Given this list of marker genes Serpine2, Ppard, Dynll1, Serpinc1, Rangap1, Arhgap23, Prss22, Inka1, Aph1b, Lgmn, Ercc5, Rictor, Tnfrsf10b, Rgs18, Serpina3c, Rptor, Cd55, Pdzd11, Naip6 (NCBI Gene Id 272660), Frmd7, Ccnd2, Serpinb1a, Igfbp3, Krtcap2, Chn2, Serpinb5, Dennd6b, Noxa1, Arhgap42 (NCBI Gene Id 71544), Dennd2d, Grtp1, Rubcn, Stx4a, Sos1, Ppp2r1b, Agfg1, Ppp2r2d, Timp2, Ppp1r15a, Spock3, Scgb1a1, Ppp1r1c, Rapgef2, Eef1b2, Serpina1d, Csnk2b, Guca2b, Lrp6, Pak2, Ghrl, Gprc5b, Mycbp2, Birc5, Slc27a1, Nherf4, Wrnip1, Ppef2, Rgs11, Bcl2l1, Dpep1, Ppp4r4, A2m (NCBI Gene Id 232345), Cdca2, Eed, Cmya5, Tnfaip8, Eps8l3, Rabep1, Lars1, Dennd4a, Afap1l2, Arhgef16, Prdx3, Vsir, Iqsec2, Acap2 (ArfGAP with coiled-coil, ankyrin repeat and PH domains 2), Pik3r1, Abi1, Lck, Hsp90ab1, Ctsh, Cstdc4, Bmp2k, Serpina6, Stxbp5l, Ppp6r1, Agap3, Rapgef1, Map3k12, Wfdc2, Dnaja3, Limk1, Serpina1a, Wbp11 (WW domain binding protein 11, NCBI Gene Id 72457), Sgsm2, Eif2b5, Cib1, Prkag2, Guca1b, Psd, Nanos1, Etaa1, Cst5, Sgsm3, Ranbp10, Tbc1d30, Atg14, Serpinb6e, Serpine1, Gpsm1, Psd3, Elmod3, Psme3, Hnrnpc, Wfdc9, Iqgap3, Sipa1l1, Chn1, Fam20a, Pot1b, Calm1, Rgs8, Irs3, Stfa2l1, Cry2, Wdr91, Serpina7, Gnb5, Irs2 (insulin receptor substrate 2), Wdr20rt, Garnl3, Lamtor4, Ppp1r16b, Rgs2, Clstn3 (NCBI Gene Id 232370), Chrm4, Tom1l1, Fgf13 (NCBI Gene Id 14168), Sh3bp4, Arhgap39, Pdgfb, Srgap2, Camk2n1, Serpind1, Ube2n, Fbxo8, Lrrk2, Gprc5a, Mt3, Arhgef37, Lamtor5, Dgki, Dnttip1, Glmn, Spint3, Arhgef6, Rbck1, Ltf, Nprl2, Spry2, Ccnb1, Rasa4, Ppp3r1, Apoc3, Pycard, Cast, Myo9b, Csnk2a1, Macroh2a1, Cd40lg, Fgd3 (NCBI Gene Id 76091), Ccne1, Serpinb9f, Psme2, Cyb5b, Ahsg, Lmtk2, Sirt1, Dmwd, Ppp1r14b, Calml4, Agfg2, Ccnj, Wfdc15b, Serpina5, Cd24a, Rps15, Cip2a, Mapk8, Psmf1, Tbc1d4, Ttn, Cd55b, Gpihbp1, Als2, Tgfbr2, Hexim1, Pbp2, Rcan1, Ppp4r3c2, Igtp, Rgs3, Htra2, Rasal3, Arap1, Gmip, Cstb, Arhgef33, Pkia, Pzp, Bmp7, Col7a1, Wap, Ppp1r10, Gdf2, Oas1d, Sumf2, Timm50, Tnfsf14, Acrbp, Ing2 (inhibitor of growth family, member 2), Smtnl1, Arhgef5, Tank (TRAF family member-associated Nf-kappa B activator), Rin1, Oaz1, Spata13, Csta3, Nap1l2, Azin2, Gipc1, Thbs1, Timp1, Deptor, Trib2, Avp (arginine vasopressin), Pik3r5, Col6a3, Cox6a1, Tcl1b2, Serpina3g, Cst9, Arhgap12, Wfdc18, Otub1, Cab39, Ppp1r14d, Arhgap33, Tbc1d15, Mob3b, Rplp1rt, Pif1, Rasgrf2, Dennd5a, Eif2b3, Thada, Cep43, Ssbp1, Arhgef4, Itih4, Akt1, Ppp2r2c, Dennd3, Ncf4, Mat2b, Prkar1b, Smr2l, Foxl2, Pin1, Eef1a1, Ppp4r3a, Dgkz, Ppp4r3b, Ankrd42, Dnmbp, Pex12 (NCBI Gene Id 103737), Arhgef2, Rtkn, Rgs20, Washc1, Ocrl, Fbxo5, R3hdml, Cav1, Eef1d, Fgd1, Arhgap10, Itsn2, Nrg1, Parp9, P2rx7, Cdkn2c, Dock4, Arhgap6, Spink5, Pdcd5-ps, Arfgef3, Crim1, Gprc5d, Prex2 (NCBI Gene Id 98394), Rgl3, Serpinb13, Dennd4c, Spint1 (NCBI Gene Id 20732), Ccdc88c, Wdr4, Naa16, Itgb1bp1, Prkar1a, Serpinb7, Kng2, Iqgap1, Ppp6r3, Cyth1, Cdc37, Acsl1, Tbc1d9b, Oaz3, Git2, Ccnq, Ppp1r8, Wnk1, Psd4, Sec23a, Serpinb9c, Slc39a10, Ccne2, 2810408A11Rik, Tifab, Ring1, Tmbim6, Rangrf, Angptl4, Rcc2, Serpinb3d, Hspa5, Cstl1, Pde8a, Wdr48, Rgs17, C9orf72, Serping1, Kndc1, Spink10, Tfpi, Ppp1r1b, Rab3gap2, Rac2, Tbc1d10b, Grm5, Arhgef18, Nupr1, Gbp2, Wfdc15a, Dock9 (NCBI Gene Id 320710), Il6st, Vav1, Phactr4, Lilrb4a, Stfa3, Pin1rt1, Serpinb9, Pygo2, Qars1, Serpina16, Ophn1, Ptp4a2, Serpina3b (serine (or cysteine) peptidase inhibitor, clade A, member 3B), Sirt6, Cdkn1a, Agap1, Hspb1, Tbc1d12, Fzr1, Nucb1, Rapgefl1, Sirpa, Ccnh, Hrg (NCBI Gene Id 94175), Psenen, Tbc1d9, Apoa4, Serpinb9h, Igbp1b, Arhgdia, Pi16, Bccip, Gchfr, Scg5, Map2k2, Phactr3, Ankle2, Sh3rf2, Dcp1a, Lamtor2, B3gat3, Git1, Cks1b, Adap1, Gbp4, Hps1, Ankrd27, Arhgef1 (Rho guanine nucleotide exchange factor 1), Fgd2, Pinx1, Bmi1, Stk11, Wfikkn2, Tsacc, Ppp1r12b, Mob2, Apoe, Racgap1, Ppp2r2b, C4b, Csn2, Tcl1b1 (T cell leukemia/lymphoma 1B, 1), Ric8b, Dock2, Dock7, Bmp4, Itih3, Abr, Spdya, Apobec1, Ppp1r12a, Anxa2 (annexin A2), Smr3a (NCBI Gene Id 20601), Serpinh1, Rps7, Serpina1e, D1Pas1, Ralgps1, Ppp3r2, Npm1, Dis3, Grm7, Plekhg1, Ins1, Ncf2, Azin1, Rpl11, Llgl1, Dtx3l, Ankrd54, Sgsm1, Apoc2l, Plekhg6, Gnai1, Mstn, Arfgap2, Mob1b (MOB kinase activator 1B), Erbb3, 1700006A11Rik, Rad50, Serpina10, Prkag1, Elp2, Aph1a, Uri1, Ibtk, Arhgef3, Ugt1a10 (NCBI Gene Id 394430), Stfa1, Agt, Pkig, Hps4, Mbip, Cab39l, Madd, Plcg1, Psmd1, Apba3, Apc, Renbp, Sh3glb1, Preb, Col28a1, Arhgef39, Nlrc4, Rp2, Rcan2, Psmd14 (NCBI Gene Id 98839), Mlst8, Rap1gap, Cst11, Ppp1r27, Myo9a, Serpinb6c, Ambp, Calu, Prkag3, Gbp5, Bmp2, Serpine3, Raf1, Ncf1, Ppp1r9b, Wars1, Lgals9, Kidins220, Spink8, Arhgap31, Dock5, Ppp1r12c, Tbc1d1, Lyn, Spink13, Stap1 (NCBI Gene Id 56792), Coq9, Tcl1b5, Ccny, Gtf2f1 (general transcription factor IIF, polypeptide 1), Gopc, Gdi1, Elmod2, Spock1, Rhoh, Pik3r3, Malt1, Ppp1r26 (NCBI Gene Id 241289), Itih1, Wfdc12, Ccnd3 (cyclin D3), Serpina1f, Cdk5r2, Elfn2, Serpinb9d, Atp2a3, Rapgef6, Gna11, Map2k1, Gapdhrt2, Alkal2, Ccdc88a, Ppp4r1, Pcp2, Serpinb11, Fbxw7, Arap3, Ppp1r2, Evi5, Gpsm3, Dennd2a, Nek9 (NIMA (never in mitosis gene a)-related expressed kinase 9), Rasa2, Rasgrp3, Clps, Gm7298, Ramacl, Mug2, Hmgb1, Arhgef10l, Srgap1, Rps27l, Ltk, Spred1, Bcl2a1d, Dnajc3, Arhgdib, Kalrn, Tbc1d8b, Als2cl (NCBI Gene Id 317635), Svbp, Taok1, Arhgef40, Psmc3ip, Ppp1r14bl, Itprip, Pmp22, Mcf2l, Ramac, A2ml1, Bcas3, Naa15, Ngb, Klf4, Furin, Rapgef4, Pkib, Ptprc, Rock2 (NCBI Gene Id 77848), Tmx1, Suz12, Trem2, Simc1, Ect2, Ppp1r3b, Fgd5, Arfgap3, Wdr41, Rap1gds1, Wfdc13, Spint2, Pik3r2, Tns3, Topbp1, Mid1ip1, Dele1, Areg, Wdr81, Pgam5, Nckap1l, Cdc20b, Rab3ip, Arhgef19, Dennd2c, Ppp1r15b (NCBI Gene Id 98406), Nkx3-1, Ddost, Ptn, Tbc1d24, Wfdc5, Rapgef5, Ppp2r3d, Irgm2, Tbc1d8, Arhgef25, Wfdc1, Bsn, Arhgap25, Wdr6, Smr2, Park7, Akt1s1, Tbc1d25, Rabep2, Parva, Irs1, Rcc1l, Kng1, Arhgap1, Xiap, Tiam1, Polg2, Cstdc6, Nprl3, Gdpgp1, Atg13, Nbn, Pik3r6, Serpina3j, Ccno, Lamtor1, Gm28729, Serpina1c, Rasgrf1, Adap2, Tbc1d22b, Nucb2, Obscn, Pinlyp, Serpinb1c, Gapvd1, Gripap1, Rgn, Smo, Cdkn2b, Noxo1, Serpina3f, Serpinb3a, Spink6, Rgs9, Serpinb3c, Mcf2, Dennd1a, Ppp2r2a, Trp53, Stxbp5, Vcp, Mtss2 (MTSS I-BAR domain containing 2), Ccnjl, Ltc4s, Bcl10, Brpf1, Ezhip, Serpina11, Efcab11, Mon1a, Itsn1, Ajuba, Net1, Syngap1, Wdr20, Arhgap26, Ccnc, Capn3, Ccnl2, Cst12, Gckr, Csta2, Bst2, Anxa1, Serinc5, Fetub, Tcl1, Birc3, Fam13b, Ensa, Wnt11, Stfa2, Inca1, Parp16, Serinc1, Ngef, Ccni, Rasgef1a, Plekhg2, Arhgap17, Rps6ka1, Ppp1r37, Wdtc1, Birc2, Sh3pxd2a, Strit1, Pak1ip1 (PAK1 interacting protein 1), Hyal2, Pcsk1n, Gna12, Ptpa, Myoz1 (NCBI Gene Id 80553), Serpina9, Igf2, Ccna1, Igbp1, Cst13, Naa25, Ralgapb, Sorl1, Eif5, Sipa1l3, Eif2b2, Serpina12, Ralgapa1, Ppp1r14c, Arf1, Ccng1, Insr, Hmgcr, Cbx8, Dennd1c, Rapgef3, Igfbp2, Wfdc11, Guca2a, Gpsm2, Mcrs1, Ralbp1, Arhgap35, Htr2a, Ywhab, Cst7, Cdkn2a, Gcn1, Ugt1a8, Ppp6r2, Vil1, Iqgap2, Cdc20, Spink2, Ccnb3, Sh3bp5l, Mug1, Arhgap19, Arhgap11a, Arrb1, Arhgef12, Tex24, Ppp4r2, Sbf2, Tiam2, Pdcd5 (programmed cell death 5), Gm1527, Htr2b, Prkar2b, Ercc6, Msx3, Fbln1 (NCBI Gene Id 14114), Ccnt1, Sipa1l2, Serpinf1, Ddx3x, Rpgr, Plcd4, Btc, Ppp2r5d, Rab3il1, Tbc1d21, Sec23b, Pi15, Sav1, Akap11, Ralgps2, Ngf, Phactr1, Tbck, Arhgap21, Ucn, App, Prpsap2, Igf1, Chml, Btk, Nlrp1a (NLR family, pyrin domain containing 1A), Itga1, Cwf19l1, Cflar, Rcan3, Rps20, Rasgrp1, Epgn, Arhgap5, Prdm14, Fermt2, Rinl, Cpeb2, Nrp1, Birc6, Arhgef10, Serpinb2, Cks2, Rgcc, Nlrp1b, Dnmt3l, Prex1, Elmo1, Tiprl, Lamtor3, Tgfa, Prkch, Cyth4, Ppp1r36, Spint4, Umodl1, Spink12, Cd33, Bin1, Styxl1, Arl2bp, Dennd6a, Sh2d3c, Gnas, Tbc1d10c, Acvr2b, Serpina3i, Rheb, Ube2l3, Snca (synuclein, alpha), Trmt112, Rpl23, Kdm5a, Arhgap45, Vac14, Rpl37, Timp4, Styx, Abce1, Map3k13, Ppp2r5c, Ctla2b, Dock10, Ric8a (RIC8 guanine nucleotide exchange factor A), Tbc1d2b, Iqsec3, Dock1, Serpinb8, Sfrp2, Sln, Plce1, Cox6a2, Gnaq, Ccz1, Gm2a, Txnip, Rgs7, Apoa1, Camk2n2 (calcium/calmodulin-dependent protein kinase II inhibitor 2), Serpinb1b, Stard13, Arhgap18, Rasa3, Tesc, Arhgap44 (NCBI Gene Id 216831), Arl1, Serpinb9g, Gskip, Ccnt2, Sec61b, Rgs16, Wfikkn1, Hspd1, Tmem225, Clpx, Arhgef15, Arhgap9, Tbc1d20, Psme4, Samd15, Naip1, Prkce, Gdi2, Ccl8, Nlrp2, Sos2, Ppp1r11, Itih2, Dock6, Cd27, Birc7, Hexim2, Mapk8ip2, Spink11, Arhgap8, Bcr, Cdkn1c, Dock11, Fnip1, Elp4, Dgkq, Spry4, Gprc5c, Eif2b4, Arf4, Hbegf, Dock3, Rplp1, Plaa, Bad, Ccng2, Arhgef7, Ranbp2 (NCBI Gene Id 353053), Vav2, Asap2, Chp1, Arhgap36, Bod1, Socs3, Ppp2r5e, Ereg, Prpsap1, Syde1 (NCBI Gene Id 71709), Eps8l1, Bcar3, Atp2b4, Mtcp1, Hsp90b1, Arhgef9, Pcolce, Styx-ps, Lrcol1, Pabir2, Src, Chm, Flcn, Ppp2r5b, Trib3, Abhd5, Rack1, Socs1, Acd, Farp2, Calm5, Naip2, Iqsec1, Rcc1 (NCBI Gene Id 66739), Calm4 (calmodulin 4), Cdkn2d, Csta1, Ncor1, Wfdc10, Cstdc1, Pim1, Ranbp1, Rgs5, Cst8, Alk, Serpina3n, Sbf1, Rin2, Tbc1d5, Prdx5, Serpina1b, Tbc1d2, Rasgef1c, Adgrb3, Prkd1, Slx4, Arhgap20, Dpm3, Dab2ip, Prkra, Slc38a9 (NCBI Gene Id 77071), Fgd4, Arhgap32, Plekhg5, Acap1, Lilrb4b, Tescl, Adipoq, Kat2b, Tagap, Asap3, Dbf4, Ccnb1-ps, Dennd1b, Ncstn, Ugt1a1, Serpinb3b, Rnh1, Nos2, Dcp1b, Arhgap4, Notch1, Rarres1, Eps8l2, Stradb, Thy1, Tbc1d16, Slit2, Dennd5b, Cnep1r1, Cd109, Tab1, Calm2, Hopx, Prr5, Cit, Tbc1d14, Rab3gap1, Ralgapa2, Hsp90aa1, Tbc1d17, Mob3a (MOB kinase activator 3A), Plekhg3, Uchl5, Psmd3, Dlc1, Hc (hemolytic complement), Arfgef2, Itih5, Egf, Serpinb12, Arhgap27, Grem1, Mansc4, Ppt1, Clpsl2, Serpinb6a, Casp3, Serpina3m, Cnppd1, Mrln, Gbf1, Septin2, Cdkn1b, Psmd2, Spink7, Cyth2, Ppp1r35, Tbc1d22a, Plcb1, Rap1gap2, Akap13, Ngp, Depdc1b, Nanos3, Rasgrp4, Dennd4b, Mnat1, Arhgap22, Rpl37rt, Sh3bp1, Casp8ap2, Smap1, Ppp2r5a, Guca1a, Cstdc5, Rasa1, Egfr, Sergef, Oaz2, Rasgrp2, Depdc1a, Pcgf2, Apoc1, Hras, Apoc2, Pot1a, Nlrp3 (NLR family, pyrin domain containing 3), Tprn, Gmppa, Ppp1r16a, Ccar2, Prkar2a, Eif2b1, Dad1, Serpini1, Elp3, Tbcd, Cks1brt, Cdc42ep2, Rabgap1l, Ahcyl1, Arhgap15, Arhgef38, Gapdh, Aph1c, C1qbp, Adrm1, Vrk3, Rgs14, Ppp1r7, Rpl5, Tgfb1, Fgd6, Fry, Krit1, Ppp2r3a, Ccl5, Serpina3k, Arhgap24, Wfdc21, Mob3c, Arhgdig, Apoa2, Rabgap1, Gnaz, Stard8, Rasal1, Cst3, Asap1, Pdpk1, Ugt1a7c, Apaf1, Pik3ip1, Arhgap30, Parp8, Psme1, Tcl1b3, Serpinf2, Spred2, Mmp25, Entrep1, Dffa, Cstdc3, Prkrip1, Sec14l2, Nf1, Nanos2, Arpp19, Fn1, Llgl2, Spink4, Apoh, Tsc2, Serpinb9b, Vegfa, Ralgds, Cavin4 (caveolae associated 4), Prkcd, Gstp1, Nol3, Thg1l, Evi5l, Rgp1, Alkal1, Dmpk (dystrophia myotonica-protein kinase), Rgs6, Nck1, Papln, Mgat5, Ppp4r3c1, Rap1a, Dusp19, Sdhaf4, Wfdc8 (NCBI Gene Id 277343), Ambra1, Arhgef17, Ten1, Epo, Apoa5, Ncs1, Ccnl1, Adgrv1, Dusp22, Wfdc16, Agap2, Gapdhrt, Fip1l1, Coq8a, Arhgap29, Eppin, Sipa1, C3, Pebp1, Sh3pxd2b, Ccl3, Cdk5r1, Ccnd1, Pik3ca, Faf2, Mgst2, Inhca, Atad3a, Reck, Farp1, Rgs10, Tfpi2, Arhgef28, Pttg1, Dpm2, Jun, Tcl1b4, Btrc, Rgs4, Ppp1r1a, Naip5, Dus2, Arfgap1, Serpinb10, Grb2, Acap3, Ski, Smap2, Parp6 (poly (ADP-ribose) polymerase family, member 6), Ccna2, Pten, Trio, Alox5ap, Nolc1, Rin3, Ric1, Wfdc3, Rgl2, Cabin1, Aplp2, Depdc5, Ppp1r14a, Slpi, Gpc3, Serpini2, Arfgef1, Usp14 (ubiquitin specific peptidase 14), Arhgap28, Nsmaf, Pdgfra, Casp8 (NCBI Gene Id 12370), Abca2, Sesn2, Gclm, Ccnb2, Serpinb6d, Pcna, Gbp2b, Elmod1, Tbc1d7, Aim2, Serpinb6b, Ppp1r17, Timp3, Ccnk, Sh3bp5, Map3k20, Srgap3 (NCBI Gene Id 58906, SLIT-ROBO Rho GTPase activating protein 3), Ppp2r1a, Anp32e, Pcolce2, Crb2, Rps6ka3, Serpina3a (serine (or cysteine) peptidase inhibitor, clade A, member 3A), Ins2, Elfn1, Usp6nl, Arhgef11, Rgl1, Cox17 (cytochrome c oxidase assembly protein 17, copper chaperone), Arap2, Dennd2b, Vav3, Dazap2, Mob1a, Anxa3, Rasgef1b, Fam47e, Dennd10, Dock8, Tbc1d13, Rgs1, Adrm1b, Trib1, Irgm1, Syde2, Arhgap40, Gpr158, Pde6d, Wfdc6a, Dennd11, Vps9d1, Rgs12 (regulator of G-protein signaling 12), Ywhae, Wfdc17, Ccnf, Rabif, Inka2, Socs5, Fyn, Psd2, Mtmr9, Gapdh-ps15, Spink1, Daxx, Serpinb9e, Mapk9, Smcr8, Lxn, Angpt4, Brcc3, Angptl3, Wfdc6b, Calm3, Pelo, Pabir1, Strada (NCBI Gene Id 77993), Tefm, Tbc1d10a, Cyth3, Ugt1a9, Ctsc, Rabgef1, Gas6, Prnp, here is a description of the gene set: Binds to and modulates the activity of an enzyme. Mouse Gene Set: GOMF_ENZYME_REGULATOR_ACTIVITY species: Mus musculus